Given this list of marker genes TBX21, EP300, ATF2, SOX13, PCK1, CD4, KCNK18 (potassium two pore domain channel subfamily K member 18), BRAF, CCR6, TNFSF8, HLA-DRA, FZD5, HLX, LGALS1, CD28, BTN2A2, KLRC1, ACTL6A, IL21, MAFB, ANXA1, CTLA4, CTSL, BATF, HLA-G, CTNNB1, FOSL2, PIK3CD, IFNG, ENTPD7, SMARCE1, ARMC5, VSIR, TP53, NRARP, IL27, JAK3, TMEM131L, FGL2, B2M (beta-2-microglobulin), USP44, FOXJ1, CD80, IL18, SMARCD1, LILRB4, ZEB1, SOS1, CD83, CBFB, JMJD6, ADA, PIK3R6, LIPA, SOX4, ATG5, IL6R, AIRE, KIT, GBA1, IL2RA, SMARCB1, PTGER4, RORC, DTX1, KDELR1, CCR7, RUNX3, TNFSF18, VAV1, DLL4, CRTAM, BMI1, CAMK4, TRAF3IP2, PRDM1, IFNA2, ARID2, PTPN22, FZD7, PIK3R2, MR1, LFNG, RHOH, RORA, CD69, SRF, TGFBR2, ADAM17, KAT7, PTCRA, LGALS9, RUNX2, ZBTB1, IRF1, IL7R, THEMIS, PSMB11, PRDX2, NLRP3, RAG1, RC3H2, SP3, PRKCZ, IL6ST, IL1A, GLI2, TNFSF4, CCL19, SHH, WNT1, CD86 (NCBI Gene Id 942), MDK, RAG2, SOD1, ITPKB, RSAD2 (radical S-adenosyl methionine domain containing 2), AP3B1, CR1, GPR89A, IL6, CD3E, BAD, STAT6, CD2, WNT4, NFKBIZ, SLAMF6, IL4R, CDK6, STK11, ACTB, VNN1, SMARCD2, ICOS, PREX1, TCIRG1, ZFP36L1, PIK3R1, ZBTB16, GATA3, JUNB, NFATC3, PPP3CB (protein phosphatase 3 catalytic subunit beta), TSC1, BRD2, SLC46A2, STAT4, NFKBID (NCBI Gene Id 84807), BCL3, ZFP36L2, CCR2 (NCBI Gene Id 90262), CD3D, RABL3, ZAP70, RELB, SEMA4A, SOCS1, ATP7A, AP3D1, STAT5B, IHH, EOMES, BRD7, PRKDC, SMARCC2, NCKAP1L, IFNL1, NHEJ1, IL12B, ZC3H8, FOXP1, CD8A, RC3H1, IL4, CD46, PKNOX1, GPR89B, LMBR1L, CLEC4D, ZBTB7B, CD3G, CCR9, FCER1G, FANCD2, MEN1, SPN, DNAJA3, TNFRSF9, HMGB1, IL7, ARID1B, SLC4A2, LY9, SYK, FOXO3, LEP, BCL11B, ACTL6B, ADAM8, PTPN2, IL1B, RUNX1, CHD7, ZMIZ1, OPA1, AMBRA1, CD74, PIK3R3, KAT2A, XBP1, IL23A, BMP4, LEF1 (lymphoid enhancer binding factor 1), PSG9, RARA, CLPTM1, ZNF683, GLI3, FADD, BCL6, RPL22, SPI1, PTPRC, GPR18, PATZ1, SMARCD3, LIG4, WNT10B, KAT5, JAG2, RHOA, TBK1, NCAPH2, STAT3, MTOR, LAG3, PLA2G2D, TMEM98 (NCBI Gene Id 26022), ARID1A, FOXP3, RASGRP1, SOCS3, ASCL2 (NCBI Gene Id 430), IKZF3 (IKAROS family zinc finger 3), ZFPM1, SH3RF1, SART1, LEPR, TCF7, LOXL3, PRELID1 (NCBI Gene Id 27166), CLEC4G, RIPK3, SHB, METTL3, TOX, SOX12, PDP2, HLA-DRB1, CLEC4E, ERBB2, DROSHA, STAT5A, GPR65, IL1RL2, ZC3H12A, IL2RG, LILRB2, BRD4, NKAP (NFKB activating protein), SMARCC1, EGR1, SPINK5, NKX2-3, PBRM1, PHF10, KMT2A, CD1D, TESPA1, KLHL25, DUSP10, FOXN1, DOCK2, LCK, ITK, ABL1, MIR30B, SOCS5, FZD8, MALT1, BCL2, ICOSLG, IL23R (NCBI Gene Id 94006), IL4I1, IL15, SMAD7, GPR183, RIPK2, CRACR2A, SASH3, SOS2, PNP, FANCA, CARD11, SMARCA4, IRF4, HLA-DOA, IL12RB1, FUT7, JAK1, SMARCA2, IL18R1, CD27, IFNB1, IL36B, EGR3, TNFSF9, IL2, PRR7, CDKN2A, TGFB1, CYP26B1, MYB, ITPRIPL1, CYLD, MIR21, here is a description of the gene set: studied in species Homo sapiens The process in which a precursor cell type acquires characteristics of a more mature T-cell. A T cell is a type of lymphocyte whose definin characteristic is the expression of a T cell receptor complex. Human Gene Set: GOBP_T_CELL_DIFFERENTIATION